The following is a description of a gene set: Photoreceptor layer loss on macular OCT Loss of the outer nuclear layer (photoreceptor layer) as assessed by ocular coherence tomography. Human Gene Set: HP_PHOTORECEPTOR_LAYER_LOSS_ON_MACULAR_OCT studied in species Homo sapiens, and this is the list of marker genes: PMM2, SLC6A6, TRNT1, CLCC1, HLA-A